Given this list of marker genes FASTKD3, BLVRA, COTL1 (coactosin like F-actin binding protein 1), MYO10, DEPDC1B, PARP1, CUTC, CABLES2, NOTCH2, SLC15A4, RGS14, NLK, ATXN2L, EHD4, GSDMD, PKDREJ, TTYH2, LSM2, NCOR1, E2F6, PTPRA, AXIN2, PRKCB, GSR, CBLN2, MS4A6A, CKAP2L, EI24, KIF13A, ATP6V1B2, UBTF, LDAH (NCBI Gene Id 60526), CHIC2 (cysteine rich hydrophobic domain 2), WDR83OS, PEF1, PDXK (pyridoxal kinase), AP2M1, ZHX1, PKP4, ZMYM4, WDR41, PSD4, NEK2, CAB39, FGFR1, SLC15A2, CHCHD4, POT1, CHD9, H2AX, SNIP1, TMEM202, DNA2, SLC35B4, PLEKHB2, VPS11, TMEM87A, COG1, TGFB1, TOGARAM1, AP3S1, LRRC8A, PAM, FLOT2, NCOA6, MTFR1L, RBM45, RFNG, TFCP2, EPN2, NDRG3, C6orf62, FANCG, APOBEC1, UBR3, ZDHHC24, FRRS1, ZIK1, ORAI3, CLCN4, ATP5F1A, COG6, ARV1, CCSAP, SEC11A, ASNSD1, PEG3, INPP5F, TNS3, SNX12, NIN, QSER1, SUV39H1, PTGES2, MTA1, G6PC3 (glucose-6-phosphatase catalytic subunit 3), RPS26, SLC25A6, GPR83, NAGPA, LCMT2, EVI2B, PROB1, TSPAN8, POLK, TAS1R1, CDK18, MAP2K7, ZNF212, CIPC, MRPL10, KLRK1, USF2, GYG1, CD93, ZKSCAN8, CORO1C (NCBI Gene Id 23603), TNKS, ZMYND11, C4orf46, RAB14, ARHGDIA, CD300A, CLEC4A, IDH3B, DDX3X, CITED2, ADGRG3, HS1BP3, UQCRFS1, GID4, RCC2, ADAM17, GATAD1, TGFA, MORF4L1, PLEKHM2, SEPTIN11, HYAL2, NDEL1, TMEM248, LYRM4, STAT6, SRXN1, MAL2, ARHGEF1, NARS2, DGKZ, E2F8, ZNF518B, ARHGAP30, PRXL2A, MBD3 (NCBI Gene Id 8931), LRIG1, ARHGAP39, MYOF, SNX8, DHX34, DPP9, MBTPS2, STX6, NPEPL1, MAP7D1, FFAR4, ANKRD13A, DHRS3, GTF2H3, TMEM222, SH3BGRL3, ING1, PRC1, UTP15, ABCB6, CYP2R1 (NCBI Gene Id 79445), FCHSD1, GCFC2, SMC2, SLC41A3, NDUFC1, LRP1, TSPAN5, LGALS3, GET1, DENND11, PCBP1, DYRK3, PCBP2, BMP2K, PTCD2 (NCBI Gene Id 79810), GPNMB, RACGAP1, SLC29A3, AQP7, PSMB11 (NCBI Gene Id 122706), ACAD8, ARFGEF3, KLHL6, STAC2, RASA1, CYP4F3, here is a description of the gene set: Genes up-regulated in CD8 T cells: healthy versus CLL (chronic lymphocytic leukemia). from publication Görgün G, Holderried TA, Zahrieh D, Neuberg D, Gribben JG (PMID 15965501) studied in species Homo sapiens Human Gene Set: GSE8835_HEALTHY_VS_CLL_CD8_TCELL_UP To examine the impact of tumors on the immune system, we compared global gene expression profiles of peripheral blood T cells from previously untreated patients with B cell chronic lymphocytic leukemia (CLL) with those from age-matched healthy donors. Although the cells analyzed were not part of the malignant clone, analysis revealed differentially expressed genes, mainly involved in cell differentiation in CD4 cells and defects in cytoskeleton formation, vesicle trafficking, and cytotoxicity in CD8 cells of the CLL patients. In coculture experiments using CLL cells and T cells from healthy allogeneic donors, similar defects developed in both CD4 and CD8 cells. These changes were induced only with direct contact and were not cytokine mediated. Identification of the specific pathways perturbed in the T cells of cancer-bearing patients will allow us to assess steps to repair these defects, which will likely be required to enhance antitumor immunity. Gene expression profiling was performed to determine whether CLL cells induce changes in T cells in patients with CLL.